The following is a description of a gene set: species: Homo sapiens Human Gene Set: GOBP_REGULATION_OF_INHIBITORY_SYNAPSE_ASSEMBLY Any process that modulates the frequency, rate or extent of inhibitory synapse assembly., and this is the list of marker genes: CLSTN3, CBLN1, LHFPL4, SEMA4D, SEMA4A